Given this list of marker genes NSMCE2, GDF5, FLNB, XRCC4, LBR, here is a description of the gene set: Severe short-limb dwarfism Human Gene Set: HP_SEVERE_SHORT_LIMB_DWARFISM species: Homo sapiens